The following is a description of a gene set: The change of a skeletal muscle satellite cell from a mitotically quiescent to a mitotically active state following exposure to some activating factor such as a cellular or soluble ligand. In adult muscle, satellite cells become activated to divide and differentiate in response to muscle damage. species: Mus musculus Mouse Gene Set: GOBP_SKELETAL_MUSCLE_SATELLITE_CELL_ACTIVATION, and this is the list of marker genes: Sox15, Gjd4, Snhg15, Capn3, Ephb1, Kpna1, Klf5, Xirp1, Wnt7a, Megf10 (multiple EGF-like-domains 10)